The following is a description of a gene set: species: Homo sapiens The activation signaling of transcription factor nuclear factor-kB (NF-kB) plays central role for immune system. One of key kinase mediating this pathway is TAK1 in adaptive and innate immunity. However, role of TAK1 in B cell receptor signaling is still unclear. To know effects of TAK1-deletion on the gene expression induced by anti-IgM, we performed the time course analysis in comparison of wild type with TAK1-deleted splenic B cells. Genes up-regulated in B lymphocytes with MAP3K7 knockout: untreated versus anti IgM for 6h. Human Gene Set: GSE41176_UNSTIM_VS_ANTI_IGM_STIM_TAK1_KO_BCELL_6H_UP from publication Shinohara H, Behar M, Inoue K, Hiroshima M, Yasuda T, Nagashima T, Kimura S, Sanjo H, Maeda S, Yumoto N, Ki S, Akira S, Sako Y, Hoffmann A, Kurosaki T, Okada-Hatakeyama M (PMID 24833394), and this is the list of marker genes: ZBTB39, TSPAN5, LBH, PABPC1L, CCS, TMEM151B, COX16, WDR45, QRFPR, DNAJC18, CD33, MIF, GMPR, IRF4, ZFTRAF1, ABI1, NBEA, SMAD5, YEATS4, TSEN34, WDR41, FAM3A, OPHN1, TPRG1, APBB3, CA9, TECR (NCBI Gene Id 9524), SNX33 (sorting nexin 33), TFG, PTPRM, CAVIN1, ANGPTL7, PTPRJ, SLC15A5, METTL25B, SLC30A2, PNPO, HIPK3, SOCS3, GTF2H2, WRN, ZMAT5, DIDO1, UBE2B, SOCS4, MIGA1, IER3, RCAN3, KRT222, SV2B, LMOD2, NSUN3, TSPAN8, COL11A1, IPCEF1, SELENON, CDYL, B3GNT9, TMEM64, TERB2, KYNU, MAOA, SNAP29, PHETA1, TMEM39A, OPN1SW, PRR3, FBXW5, SLAMF1, SCCPDH, RCN1, NEIL1, TBP, KAT7 (lysine acetyltransferase 7), POLQ, GID4, DAG1, SOCS7, AUH, NELFB, LHCGR, PDCD10, YES1, CPNE1, CYP20A1, LLGL1, SBNO2, KBTBD7, TPK1, TMEM74, CDK2AP2, RAB39A, ALOX5AP, ANKUB1, CD200, USF3, CEACAM21, ABCA13, BTLA, RAB24, SLC43A1, MAP10, RNF144B, LIN28B, POLDIP3, TIMM29, DYNC2H1, ARMCX5 (armadillo repeat containing X-linked 5), PPP1R3D, IRAK1BP1, DCAF6 (NCBI Gene Id 55827), CCDC14 (coiled-coil domain containing 14), AMZ2, SLC1A3, TNR, SMUG1, GPR108, NTAQ1, SNORD89, LONRF1, DANCR, CACNB2, IQCC, IFT70A (intraflagellar transport 70A), FAAP20, MMP20, BDNF, C1orf210, F8, MACO1, ELMOD1, WDR35, ZNF141 (NCBI Gene Id 7700), ZCCHC10, PTDSS2, YBEY, RNF113A (ring finger protein 113A), ARHGEF3, MAD2L2, ALS2, SPICE1, MKNK1, COX11, HPGD, DNAH9, WDR13, BBS4, AGK, MCRIP1, INO80, TDRD9, IL17RB, ZNRD2, BMPR1A, ZNF383, STXBP1, ZNF347, PANX2, ZBTB9, GLRB, TSPAN31, CDH1, STX6, ARMCX1 (NCBI Gene Id 51309), FIRRE, RSBN1, PADI4, INTS12, EXD2, SHFL, NDUFS8, LRRC34, CDH17, POFUT1, TRIOBP, UBE2N, FUNDC1, CRY2, SPRY3, FILIP1L, SNTG2, MPDU1, MRPS18A, SLX9, PPOX, TSPYL2, FUT4, TMEM199, INPP5E, MECP2, MAP3K2, ODAM, NRSN1, C8orf58, ERI3, ZFYVE9, GPRASP1, SDHC, MBTPS2 (membrane bound transcription factor peptidase, site 2), IFT70B